The following is a description of a gene set: Abnormality of urine bicarbonate level Human Gene Set: HP_ABNORMALITY_OF_URINE_BICARBONATE_LEVEL species: Homo sapiens An abnormal amount of hydrogencarbonate in the urine., and this is the list of marker genes: SLC34A1, NDUFAF6, OCRL, EHHADH, GATM, ALDOB